Given this list of marker genes MBOAT1, MZB1, PF4 (NCBI Gene Id 5196), IKZF3, ALAS1 (NCBI Gene Id 211), POLD1, EXOC3L2, BRCC3, C2CD5, LMTK2, COX17, PSME1, B3GNT5, BCAR3, CYFIP2, XAF1 (NCBI Gene Id 54739), RALGDS, CRISPLD2, CLIC4, RIOK1, GFI1, ACSL1, GFI1B, GIMAP8, MAPKAPK3, OTUB2, KIF22, BCL11B, NEIL3, PPP2R2A, ATP5ME, TNFAIP3, NEDD9, TUBA8, IFIT1B, CHCHD10, MSR1, NSRP1, PDGFC, JPT1, LMO4, ADD3, CP, EAPP, ZBP1 (NCBI Gene Id 81030), CTLA4, CD3D (NCBI Gene Id 915), PLCB1, IFIT3, IFI35, KIAA0040, GINS1, IRGM, CCRL2, PTPN6, HLA-E, SIPA1L1, C6orf89, SH2D1A, ZCCHC18, MANSC1, FEN1, CD47, SRGN (serglycin), ITGB7, ARHGEF37, FLT3, SEMA4A, TRIOBP, CRACDL, PTPN12, C8orf33, PROM1, PPP2R5A, GSR, LAT2, NXT1, IER5, SAMHD1, SLAMF9, RAP1GAP2, LSP1, IFIT2, ARHGAP26, ARRDC4, LITAF, RAD54B, SP110, SNRNP27, ALOX15B, PSMA2, SLC2A6, RUNX3, BTLA, FLAD1, TVP23A, KYNU, GADD45G, GPR18, INSL6, HLA-G, DHX58, BOLA2, INPP5B (NCBI Gene Id 3633), TMEM160, ANGPT1, CHIC2, ADGRG5, SLC28A2, ICOS, TINF2, CGAS, SNCA, OSM, HSD11B1, FCGR3A, SUV39H1, CXCL11, GP1BB, PYCARD, POP7, LSM4, FAAP24, EXOSC8, CD40, GBP2, NFKBIB, MMP12, CCDC167, SPIB, KBTBD11, ITGAX (integrin subunit alpha X), FAM131B, BORA, PCNA, GP9, CYSTM1, DUSP2, ATP2A3, TANK, MPC2, SOD2, NUBP1, DGKG, DDIT3, RGS1, G0S2, IL1B, ARK2C, MMRN1, TREX1, NSUN5, SAMD9L, FPR1, NR4A3, EVA1B, E2F2, MSRA, CSGALNACT2, IGLC7, ZFAND4, FCGR1A (NCBI Gene Id 50698), OLFM4, RSAD1, CORO1A, RAC2, NGDN, CLNK (cytokine dependent hematopoietic cell linker), NDUFA3, CDKN2D (NCBI Gene Id 1032), PADI2, TUBB1, ESAM, GP1BA, IL12B, S100A8, PRG3, HGD, IL36G, PEF1, PLS1, CXCL10, ABRACL, RAB37, CD274, SLC7A11, ITK, FBXL14, FASLG, PNMA1, PITPNM1, CDC25A, KCNC4, LCK, L1CAM, SNRPC, TREML2, PSMB9, JAK2, CIITA, here is a description of the gene set: IL-10 or IL-6 stimulation of control 129xC57BL/6 murine bone marrow derived macrophages in the presence of LPS. We used microarrays to detail the global programme of gene expression changes in response to IL-6 or IL-10 stimulation in the presence of lipopolysaccharide. BMDMs were isolated from control, IL-6-/-, and IL-10-/- mice on a 129XBL/6 mixed background mice and differentiated in the presence of CSF-1 for 6-7 days. Cells were scraped and plated in 6 well plates at 2x10e6/well. Cells were washed with complete DMEM and rested for 1-2 hr before stimulation with combinations of IL-10 (10 ng/ml), IL-6 (2 ng/ml) or LPS (100 ng/ml) for 45 min or 180 mins. Complete biological replicates were performed. Genes down-regulated in bone marrow-derived macrophages with IL10 knockout and 45 min of stimulation by: LPS versus LPS and IL10. from publication El Kasmi KC, Holst J, Coffre M, Mielke L, de Pauw A, Lhocine N, Smith AM, Rutschman R, Kaushal D, Shen Y, Suda T, Donnelly RP, Myers MG Jr, Alexander W, Vignali DA, Watowich SS, Ernst M, Hilton DJ, Murray PJ (PMID 17114459) Human Gene Set: GSE5589_LPS_VS_LPS_AND_IL10_STIM_IL10_KO_MACROPHAGE_45MIN_DN studied in species Homo sapiens